The following is a description of a gene set: Human Gene Set: USF_02 Genes having at least one occurrence of the motif NNRNCACGTGNYNN in the regions spanning 4 kb centered on their transcription starting sites. This matches the transcription factor binding site V$USF_02 (v7.4 TRANSFAC). species: Homo sapiens, and this is the list of marker genes: ALDH6A1, CLN3, SLC31A2, SIRT1, HOXC11, PICALM (NCBI Gene Id 8301), NALF2, DNMT3A, C4B, SOX10, STC2, RPS2, PHF20L1, TESK2, KBTBD2, NRIP3, SLC39A5, PPARGC1A, HNRNPD, POGK, TYR, REXO2, ILF3-DT, CHD6, NCOA6, CPEB4, PHF20, COMMD3, NPTX1, FGF14, NDUFA7, MACROH2A1, CPNE4, SYNPO2L, RMND1, PTGES2, TAC1, FOXD3, UBE2L6, ANKRD12, MAP4K1, HIVEP1, RLF, HNRNPA1, EIF3K (eukaryotic translation initiation factor 3 subunit K), ZFYVE26, TCF12, SASH3, COMMD8, CLCN5, BMP6, C1orf43, GPX1, NACC1, EIF3A, PFDN2, UVRAG, DRC3, LIN28A, KCNE4, OMG, DNAJB5, BRDT, TOP3A, SHOC1, GABARAP, NYAP1, GLA, AKAP12, EME1, FAM13B, ETV1, IQGAP2, DCAF13, IGSF22, SUPV3L1, CD164 (CD164 molecule), UTP14A, CALR, DHX35, LAMC2, FZD6, TGFB2, NUDC, DUSP1, DCTN4, SESN3, RAB9A, EIF4E, LRP5, MTHFD1, LHFPL6, TTLL6, SLC12A6, EGLN2, CDKN2C, BLNK, RAB3IL1, SLC23A2, FMR1, ATXN3, RHOQ, BDNF, EPB41, CREB5, HOXB5, PTMA, TSHZ2, ARMT1, CCN1, SIGMAR1, GPR65, MBD6, TRUB2, SMCR8, ATF4, LUC7L3 (NCBI Gene Id 51747), MDM1, PLS3, PPM1A, RNASE7, TIMM8A, GARRE1, VLDLR, GGN, TOM1L2, SEC11C, RUNX1, ESRP2 (epithelial splicing regulatory protein 2), LONRF3, CUTA, PIK3R1, SCRT2, ATF7IP, SMC3, IRS4, GTF2H1, HOXD10, FGF6, SPNS1 (SPNS lysolipid transporter 1, lysophospholipid), SHPK, TOGARAM1, CPT1A, LAMA3, PPCS, SNX8, CHD4, CSDE1, TNFAIP8L1, TMEM108, HTN1, ATP6V1C1, DEPDC7, TMEM132E, RHBDF2 (rhomboid 5 homolog 2), UBXN4, SEMA3A, CA14, PRDM4, SLC1A7, MTCH2, NEUROD1, ILF3, SETD2, NPM1, GTF2A1, ZMYND12, RFC1 (replication factor C subunit 1), UBE2B, PLEKHA6, RAI14, ATP6V1A, NAA50, MANF, RSPRY1, HNRNPH2, LAMTOR1, SPMIP6, VPS16, LAMP5, CYSTM1, SLC25A32 (NCBI Gene Id 81034), RNF128, TAF6L, HPSE2, EIF4B, RHEBL1, GET3, PRPS1, RNF181, AMMECR1L, HOXA11, FAM117A, IRF9, TFAP4, PFKFB1, UBR5, UMPS, AP1S2, XPO1, UBXN10, PER1, SPPL3, ZIC3, TOPORS, COPZ1, NIT1, PSME3IP1, UBE4B, ARMCX6, COQ4, CIPC, CTNS, PIP5K1A, NIPAL2, C4A, CBX5, TMEM131L, DUSP7, CCNYL1, MAT2A, METAP1D, GZMK, DUSP8, DDIT3, KLHL28, PABPC1, APLN, SQSTM1, DDX3X (DEAD-box helicase 3 X-linked), MRPL27, GNB2, STX4, BAX, STEEP1, TMEM258, MAX, UROD (uroporphyrinogen decarboxylase), PCED1A, HOXB7, SUMF1, VASH1, MCAM, OGDHL, CAPN6, BATF3, IGF2BP1, ELAVL3, STK16, THUMPD2, INTU, RALYL, ARPP19, TRMT1, SEC23IP, UBR3, CRLF1, HAPSTR1, RRAGB, TMEM132E-DT, HOXC5, NFX1, HPS5, SSR1, IQSEC1, SLC17A2, FEN1, AATF, EPC1 (enhancer of polycomb homolog 1), GIGYF2, VNN1, TCEAL7, RPS28, GRN, DVL2, CCAR1, TCERG1, FFAR2